The following is a description of a gene set: species: Mus musculus Genes from cluster 2: down-regulated in group C of tumors arising from overexpression of BCL2L1 and MYC in plasma cells. from publication Boylan KL, Gosse MA, Staggs SE, Janz S, Grindle S, Kansas GS, Van Ness BG (PMID 17483317) Multiple myeloma is an incurable plasma cell malignancy for which existing animal models are limited. We have previously shown that the targeted expression of the transgenes c-Myc and Bcl-X(L) in murine plasma cells produces malignancy that displays features of human myeloma, such as localization of tumor cells to the bone marrow and lytic bone lesions. We have isolated and characterized in vitro cultures and adoptive transfers of tumors from Bcl-xl/Myc transgenic mice. Tumors have a plasmablastic morphology and variable expression of CD138, CD45, CD38, and CD19. Spectral karyotyping analysis of metaphase chromosomes from primary tumor cell cultures shows that the Bcl-xl/Myc tumors contain a variety of chromosomal abnormalities, including trisomies, translocations, and deletions. The most frequently aberrant chromosomes are 12 and 16. Three sites for recurring translocations were also identified on chromosomes 4D, 12F, and 16C. Gene expression profiling was used to identify differences in gene expression between tumor cells and normal plasma cells (NPC) and to cluster the tumors into two groups (tumor groups C and D), with distinct gene expression profiles. Four hundred and ninety-five genes were significantly different between both tumor groups and NPCs, whereas genes were uniquely different from NPCs in tumor group C and genes were uniquely different from NPCs in tumor group D. Similar to human myeloma, the cyclin D genes are differentially dysregulated in the mouse tumor groups. These data suggest the Bcl-xl/Myc tumors are similar to a subset of plasmablastic human myelomas and provide insight into the specific genes and pathways underlying the human disease. Mouse Gene Set: BOYLAN_MULTIPLE_MYELOMA_C_CLUSTER_DN, and this is the list of marker genes: Ak7, Rgs1, B4galt6, Eid2, Sat1, Egln3, Rras2, Klf6, Saraf, Reck, Trim34a, Soat1, Kcnq1ot1, Xist (inactive X specific transcripts), Klf7, Serpinb1a, Ccnd2, Zbtb10, Rab20, Nrip1, Rnf125, Ms4a1, Slc7a11, Ptpn22, Spp1, Hs1bp3 (NCBI Gene Id 58240), H4c8, Aig1, Ctsl, Irs2, Zbtb20, Cd69